The following is a description of a gene set: Genes down-regulated in CD40L and IL-2 IL-4 IL-5 stimulated at day 1 B cell IRF4-KO versus CD40L and IL-2 IL-4 IL-5 stimulated at day 1 B cell wildtype. Human Gene Set: GSE46606_IRF4_KO_VS_WT_CD40L_IL2_IL5_1DAY_STIMULATED_BCELL_DN studied in species Homo sapiens from publication Ochiai K, Maienschein-Cline M, Simonetti G, Chen J, Rosenthal R, Brink R, Chong AS, Klein U, Dinner AR, Singh H, Sciammas R (PMID 23684984) Temporal analysis of B cell activation in vitro using CD40L and IL-2/4/5 cytokines in wild type Irf4+/+ B cells or in mutant Irf4-/- B cells harboring a tet-inducible allele of Irf4. IRF4 expression was restored, or not, in the Irf4-/- background by culturing in the presence of low or high concentrations of doxycycline. The results provide insight in the role of IRF4 expression levels in coordinating different programs of B cell differentiation., and this is the list of marker genes: S100A9, USP35, POU2F2, WDR87, SFR1, UBE2D2, CASP1, FOXS1, HBB, STK17B, CNKSR1, PGGHG, EXD3, ARHGAP24, MED6, IGLV4-60, FCMR (NCBI Gene Id 9214), XIRP2, DAZAP2, NSFL1C, FSCN2, ADGRE2, GLYCTK, TFIP11, H2BC3, IGSF9B, CYTH3, DUSP6, PRDM12, SCNN1A, SSR2, BUD31, STAG2, DDX49, ISY1, NPTXR, EIF4E2, SOD2, NCAPH2, POFUT2, PRKCH, DDX60L, B9D2, PCSK6, ERO1B, LRWD1, DOK3, CYRIA, RHBDD3, IQCD, CSGALNACT1, TMEM151B, EGR4, AZI2, TMEM163, SNCG, TBX2, SYPL1, MLKL (NCBI Gene Id 197259), LCN12, LAT2, GRIA3, QNG1, VPS37D, HPSE, IFT88, BIN3, CBY2, GP9, BST1 (NCBI Gene Id 683), DSPP, C10orf95, CLEC4E, CECR9, GNG2, CRLF3, MTMR11 (myotubularin related protein 11), LINC00954, HNRNPF, TENM1, SRA1, SPINK2, S100A12, YTHDC1 (YTH N6-methyladenosine RNA binding protein C1), FLRT2, FOLR1, ARHGEF37, MAP3K7CL, VMO1, NFKBIZ, ERP44, ATG7, TINF2, SIGLEC11, CST9, TLR1, GGT7, CORO6, ZNF511, TMEM50B, AATK, LIN37, KCNJ15, C15orf39 (NCBI Gene Id 56905), TMEM255B, GIMAP5, VNN2, KCNQ4, PRELID1, GMPPA, CARD6, PDE4B, DUSP15, MMP8, POU3F3, CHMP2A, GTF2IRD2, ACTL10 (NCBI Gene Id 170487), TRIM27, H3-3B, SLC1A4, RBM4, SPATA3, FAM161B, BAIAP2L1, SPSB2, VENTXP1, ISG20, PEX2, RCN3, H2AC13, TNFRSF8, CACNA2D3, ENSG00000261924, TMEM132A, ADRA2B, CDC26, PLD2, IL6R, PCNX1 (NCBI Gene Id 23690), MYBPC3, SIK3, CHRNE, MTHFS, DSE, VCAN, CIBAR1-DT, IRF1, TMEM50A, CARD16, RAC1, ADAMDEC1, EREG, CSF2RA (colony stimulating factor 2 receptor subunit alpha), H2AC17, ZDHHC1, PID1, SNCA (synuclein alpha), NGEF, HLA-E, DUSP16, PCDHA3, EPO, SMG9, ADA, NUP214, TELO2, PDE4D, DERL1, C6orf89, RESF1, GFOD2, VRK2, RIPOR2, WNT9A, RNF175 (NCBI Gene Id 285533), TANC1 (tetratricopeptide repeat, ankyrin repeat and coiled-coil containing 1), TCF7, THBS1, GALR2, KMT2E, PIK3R5, FPR1, ZNF839, MCM8, KCND3, FXYD4, ADH4, ABTB3, TTPAL, ZC3H18, CASP4, CCDC97, DCHS1, MXD3